The following is a description of a gene set: studied in species Homo sapiens Human Gene Set: HP_APLASIA_HYPOPLASIA_OF_THE_CORPUS_CALLOSUM Absence or underdevelopment of the corpus callosum. Aplasia/Hypoplasia of the corpus callosum, and this is the list of marker genes: MT-CO2, SOX4, KATNB1, CILK1, TMEM216, OTUD6B, SLC35B2, NUP188, B9D2, TUBB2B, MT-TQ, CFC1, NFIA, MOCS1, HNRNPU, FANCD2, KIF7, MAPKAPK5, PPP2R1A, WDR62, TBCE, GRIN1, WDR81, NAE1, PLAA (phospholipase A2 activating protein), MRPS22, PLXNA1, SLC6A9, RAB3GAP2, DDX3X, KAT6B, RALGAPA1, B9D1, PHGDH (NCBI Gene Id 94672), KANSL1, SOX3, NADK2, WARS1, VWA3B, MT-ND6, FLII, SLC1A4, ACBD6, ERCC5, POMT2, VPS11, SMARCD1, MT-TF, TCTN2, UBTF, KIF5C, CPT2, PYCR1, GNAO1, SNIP1, MID1, SLC32A1, MAF, NPHP1, SKI, TREX1, GRM7, PRKCZ, ACER3, USP7, PCGF2, CDK8, THUMPD1, EPG5, CEP120, WLS, BUB1B, RAB23, POMGNT2, TREM2, TAF2, DPF2, CHMP1A, RSPRY1, ACTB, CDC42BPB, VPS53, NEDD4L, NOVA2, ADAT3, GLI3, DYRK1A, CAMSAP1, KCNA1, COG7, HACE1, TCF12, WAC, MACF1, FGFR3, IFT140, CSPP1, PEX1, UBE3B, CUL4B, TARS2, CEP104, NKX6-2 (NK6 homeobox 2), MT-TL1, SLC25A10, PIK3CA, GFM1, NHLRC2, TXNDC15, FLVCR2, EIF2S3 (eukaryotic translation initiation factor 2 subunit gamma), IGF1R, TMTC3 (transmembrane O-mannosyltransferase targeting cadherins 3), ARFGEF2, MT-ND5, VANGL2, HIVEP2, GTF2H5, EBP, TRIM8, U2AF2, HESX1, TAF13, KNL1, SRPK3, HTRA2, UBA5, ASXL3 (ASXL transcriptional regulator 3), KCNQ2, GAS1 (growth arrest specific 1), ADNP (activity dependent neuroprotector homeobox), MFSD2A, RELN, NMNAT1, H3-3A, EXOSC1, PIGG, B3GLCT, SEC31A, GTPBP2, SALL1, PPP1R12A, PRKDC, TMEM106B, EXOC2, HNRNPK, TSEN15, POMGNT1, ADAR, PIEZO2, TAF1, OTUD5, LRP2, SNF8, ERCC3, MOCS2, CEP63, ARNT2, GAD1, RAI1, AKT3, GPT2 (glutamic--pyruvic transaminase 2), GMPPB (GDP-mannose pyrophosphorylase B), EMC1 (ER membrane protein complex subunit 1), DAG1, ARL13B, GBA2, RB1, SMC1A, GLYCTK, SMARCE1, LMNB1, ARHGAP31, TMCO1, GPKOW (NCBI Gene Id 27238), CD96, ALG8, ZNHIT3, NALCN, ZNF148, MT-CYB, LSS, ZFR, TECPR2, NANS, MINPP1 (NCBI Gene Id 9562), ACTG1, NKX2-1, METTL5, DPYD, IGBP1, SPG21, MT-TH, MBTPS2, TTI2, AP4S1, MOGS, ATRX, SHMT2, SSR4, COPB2 (COPI coat complex subunit beta 2), C12orf57, CWF19L1, KATNIP, KCTD7, MPLKIP, BLTP1, TRMT10A, DPH1, PDHB, POMK, HSPA9, PIGN, AFG2B, PPP1R15B, IFT74, SCAF4, SLC4A10, DCHS1, TMEM107, TRIP13, PRDM16, CNP, ZNF335, CBY1, RPGRIP1L, CEP135, OCA2, LIG4, GET4, PCNT, KIF5A, PIGB, WBP4, KIF26A, SASS6, CLCN4, ZNF699, KCNT2 (potassium sodium-activated channel subfamily T member 2), ATP13A2, GBA1, NFIB, DYNC2H1, TRRAP, VAC14, TUBB, MLH1, ZMIZ1, DYNC1I2, ARMC9, PITX1, B3GALNT2, CIT, SLC9A6, HIBCH, RAB3GAP1, LETM1, PDYN, TARS1, SMARCC2, ZNF462, CARS1, DONSON, ACTL6B, CEP290, VARS1, PIGQ (NCBI Gene Id 9091), MRPS16, KIDINS220, LHX3, LMBR1, COG6, CTBP1, TMEM260, GFER, PTPN23, CDH2, MED12L, NDE1, POU1F1, MAP1B, TUBB2A, WNT3, SMARCB1, CACNA1I, GLUL, POLG2, CCDC88A, FDFT1, FOXH1, NARS2, SHOC2, EXTL3, PLCB4, ERCC2, NODAL, SLC25A1, FAT4, RECQL4, FANCB, CDK10, KMT2D, DPH2, AP3B2, GRIA4, FIG4, ALDH6A1 (NCBI Gene Id 4329), PUS3 (pseudouridine synthase 3), RNASEH2C, DPYSL5, SPEN, DPAGT1, GABRD, DHX16 (NCBI Gene Id 8449), PLPBP, KDM6A, ABAT, CACNA2D1 (calcium voltage-gated channel auxiliary subunit alpha2delta 1), FOXG1, AARS1, PGAP1, KIFBP, NSD1, IBA57 (iron-sulfur cluster assembly factor IBA57), PAH, DMXL2, CDK13, SLC12A6, IER3IP1, NSUN2, MRPS25, BRAT1 (BRCA1 associated ATM activator 1), STAG2, MCM7, IFT52, LHX4, DDX59, EARS2, CNTNAP1, TCF4, PSAT1, GPC4, DYNC2I2, TUBA8, POLR3GL, ALG3, MTHFS, CASZ1, EXOC8, TMEM237, AP5Z1, RSPO2, RERE, FOXA2, CLP1, TMEM218 (NCBI Gene Id 219854), AFG2A, MT-CO3, PRMT7 (NCBI Gene Id 54496, protein arginine methyltransferase 7), MEF2C, GFM2, PIBF1, TMEM231, POLR3B, ATP6AP2, ARID2, RORA, HK1, GLI2, MT-TS2, SIX6, PROKR2, TMEM70, RARS1, TRAPPC12, TGFB1, BRAF, ERCC6, RXYLT1, AP4M1, MED25, SLC30A9, RAC3, MT-ND1, NDUFAF5, RNF113A, PAX6, RAB18, TMEM138, PLCH1, TGIF1, CRIPTO, DLL1, DOCK7, SETD2, MED12, ATN1, SMG9, UNC80, AHI1, TBC1D20, PPIL1, SLC5A6, LAMB1, ARSI, ERMARD, VPS50, PARS2, CDK5, RNU4ATAC, RNF13, DNA2, FA2H, LMNB2, EOMES, AIMP2, BUB1, GOT2, ARID1B, DCC, GPC3, MT-ND4, PMS2, DACT1, SLC35A2, WDR4, NELFA, WDR73, LONP1, ATP9A, SUZ12, CASK, NFIX, UPF3B, TOE1, CC2D2A, ALG12, UGP2, MYCN, ALDH7A1, PAFAH1B1 (NCBI Gene Id 5048), GCSH (glycine cleavage system protein H), B4GAT1, TSEN54, FKRP (fukutin related protein), SCYL2, NARS1, PIGP, RTTN, YWHAE, EIF2AK2, TRAPPC10, FBXL4, CREBBP, NRAS, CDC42, EML1, FLI1, INTS11, VAX1, POMT1, CRIPT, PNKP, RMND1, SUPT16H, DISP1, SLC25A22, L1CAM, PGAP2, CEP41, AMER1, FCSK, RNU7-1, GPSM2, COG2, APC2, MMP23B, MT-TW, OSTM1 (NCBI Gene Id 28962), DIS3L2, RAD51, PI4K2A, GABRA5, TBX4, FGFRL1, EXOC7, MCPH1, PYCR2, C2CD3, FH, ASNS, RNASEH2B, IFT27, TBCD, SACS, NTN1, CENPF, ZSWIM6, PTDSS1, YARS1, SCN3A, WDR45B (WD repeat domain 45B), TOPORS, HCCS, STXBP1, TP73, PDHA1, TSEN2, SOX2, LSM11, YY1 (YY1 transcription factor), COG4, DHCR24, USP9X, KIF14, EHMT1, ERLIN2, LARGE1, HPDL, NRROS, TSEN34, GGT1, ATL1, NEUROD2, PDPN, CPLANE1, WWOX, CDC40, POU3F3, KIAA0753, CSF1R, AP4B1, CENPE, CTNNB1, PIGU, OFD1, DYNC1H1, KDM4B, OSGEP, PORCN, VARS2, EXOSC8, TUBGCP2, PSAP, TBCK, IFT80, SCN1B, PIK3R2 (phosphoinositide-3-kinase regulatory subunit 2), LRPPRC, YIF1B, WDR26, SPTAN1, PROP1, SLC25A19 (NCBI Gene Id 60386), CRPPA, SRPX2, SIK1, GDF1, ADARB1, TOGARAM1, TUBB3, CNOT3, TRAPPC14, PPFIBP1, DCX, DHCR7, ACO2, TCTN1, NF1, UBE4B, SIN3A, RAC1, AP1G1 (adaptor related protein complex 1 subunit gamma 1), AXIN1, HNRNPR, HS2ST1, TBC1D23, UBE3A, SUFU, ALX1, FKTN (fukutin), NONO (non-POU domain containing octamer binding), COX7B, STIL, KCNAB2, VAMP2, HIC1, DARS1, TCTN3, BICD2, ZFYVE26, AMPD2, GRIA3, NDUFA2, EMX2, MTRFR, KAT5, KAT8, PPP2R3C, PPP1R21, MT-CO1, WT1, CARS2, HECTD4, SMO, FAM149B1, PUF60 (poly(U) binding splicing factor 60), GPX4, QARS1, SMARCA4, PCLO, SH3PXD2B, CNOT1, NSD2, NAA10, CDK6, EPRS1, DIAPH1, PDE6D, SARS1, DYNC2I1, EFNB1, FGFR2, INPP5E, RNASEH2A, ANKLE2, KCNT1, SPG11, BRF1, MAN2C1, ATP6V1A, ZIC2, HYLS1, DDHD2, ARID1A, CLCN3, EP300, IFIH1, COL4A1, TTC5, CTNNA2, CPLX1, CDON, ALG2, OTX2 (orthodenticle homeobox 2), LUZP1, MAPRE2, ANKRD11, CTU2, FANCI, DEAF1, CEP57, FGF8, AP4E1, ZNF423, GJC2, DDX6, CCDC174, AIFM1, MPDZ, SLC1A2, SIX3, MKS1, SETBP1, GLRX5, AHDC1, PPP2CA (protein phosphatase 2 catalytic subunit alpha), AHCY, PTCH1, BMP4, FLCN, KRAS (NCBI Gene Id 3845), ALX3, FGFR1, TNR, FRMD4A, SLC6A8, KCNK4, KIF2A, MTHFR, HSD17B4, GRIN2A, ROBO1, CYP11A1, RUSC2, ZDHHC9, GLDC, ALX4, STAMBP, VPS51, MAPK8IP3, PRPS1, NCAPD3, DNM1 (dynamin 1), WDR35, NEXMIF, TYROBP, ARX, TMEM67, KIAA0586, SVBP, GABRB1, TRAPPC6B, MDH1 (malate dehydrogenase 1), KDM5B, HUWE1, PLK4, MTOR, KIF15, FLNA, SAMHD1, POLR2A, NDUFB11, SHH, POGZ, NFU1, SCN2A, RAB34, CEP152, PDHX, FDXR, RHOBTB2, POLR3A, HRAS, ASXL1, SLC25A24, HSPG2, ZFX, SOX11, KMT2C, REPS1, LRRC32, LNPK, COG8, IQSEC2, PIGA, CDK5RAP2, RNU4-2, SF3B2, SON, TMX2, BCOR, SLC12A2, BCL11B, ZIC1, TRAPPC9, TUBA1A, POLR1C, PHC1, DNAL4, NR2F1, CDKL5, PRUNE1, KDM5A, PEX2, CYP2U1, DARS2, RPS6KA3, KDM1A, ACY1, SEPSECS, RPGRIP1, PRRX1, FBXW11, GTF2E2, COASY, ASPM, FRA10AC1, BUB3, ZEB2, NT5C2, ZBTB20, ARL3, ZBTB18, FRMPD4, NUP37, BRD4